The following is a description of a gene set: Genes predicted to be targets of miRBase v22 microRNA hsa-miR-454-3p in miRDB v6.0 with MirTarget v4 prediction scores > 80 (high confidence targets). studied in species Homo sapiens Human Gene Set: MIR454_3P from publication Chen Y, Wang X (PMID 31504780), and this is the list of marker genes: YTHDF2, SNPH, KIAA1217, HECW2, MBNL3, IGF1, TMEM170B, NPTN (NCBI Gene Id 27020), SNX2, TENT2, ZEB2, FRMD6, SBNO1, DCBLD2, THOP1, TRIM2, KLHL3, ANKIB1, RRAGD, DAAM1, ZCCHC14, TANC2 (tetratricopeptide repeat, ankyrin repeat and coiled-coil containing 2), RAB12, ITGB8, OSBPL6, CEP170 (NCBI Gene Id 9859), IKZF5, RACGAP1, PIKFYVE, CYSLTR1, KBTBD8, STIM2, TOGARAM1, AGO1 (NCBI Gene Id 26523), ZMAT3, PGM2L1, TSHZ1, DGKE, TBL1XR1, CHMP3, TMEM250, ACVR1, AAK1, TMEM9B, MED12L, BPTF, SH3D19, C2orf15, TGFBR1, MTMR10, BTBD7, SLAIN1, TAFA1, LSMEM1, BAG5, ELK3, PDZD11, MDM4, PHACTR2, LGALSL, LRP2 (NCBI Gene Id 4036), CENPO, TFCP2L1, PTPN4, HCFC2, PLCB1, R3HDM1, SLC2A4RG, SYT6, TMEM50B, ACBD3, SALL3, CCNY, RBBP8, CREB5, SOS2, PRUNE2, CD69, LRRTM2, WDR20, RFX7, ARHGEF4, WEE1, UBE2D2, CD2AP (NCBI Gene Id 25916), USP28, ZBTB4, ARHGEF26, NSD3, TMOD1, LDLR, LPGAT1, RTCA, LRP8, MYBL1, NABP1, HPRT1, MCTP1, TACC2, KIAA1191, CCDC6, ST8SIA5, ABCB7, RNF216, MDFIC, SPOCK1, CPEB1, PPP6R2, SCUBE3, PIP4P2, ARHGAP21, EPS15, FYN, PCNX1, BLCAP, INO80, KCNA4, PPARG, ITPR1, USP33, PLAA, CBY1, ARHGAP12, PURG, NRBF2, SHANK2, ATG16L1, MAP3K20, SFMBT1, DGKH (diacylglycerol kinase eta), POU4F1, ERP44, ABRAXAS2, TEX2, RUNX3, DCAF8, ABHD3, CNOT6, HS3ST5, FERMT2, LCORL, KDM2A, OTUD3, MBD2, MFSD6, CLCN6, POP7, EBF3, BRWD1, CFL2, FAT3, SERBP1, CRACD, CBX6, DEPDC1, SOCS5, LRIG1, WDFY3, TRPC3, EIF4E2, NFIB, ENPP5, HOXD1, INHBB, FMC1, CLIP1, UNC13A (unc-13 homolog A), STX6, EMX2, TRIM23, ERCC4, TGFBR2, BTF3L4, RNF38, DENND4C, BHLHE41, TES, DSG1, VCF1, ACSL1, TSC1, HOXA3, POU3F2, SNIP1, LMLN, MB21D2, ZNF3, PIGA, AKAP11, ASXL2 (ASXL transcriptional regulator 2), ESR1, TNRC6C, FRZB, GAREM1, BAHD1, RTN1, MIGA1, BMPR2, ZNF862, KATNBL1, HSPA8, PHF12, AKAP1, CBFB, SESTD1, DLC1, SPART, PRKAA1, PTP4A1 (NCBI Gene Id 7803), TLCD3A, EGLN3, JADE1, SNX31, NPNT, ATP12A, DSEL, VGLL4, UBXN2B, DPYSL2, NACC2, MLLT6, FBXO28, GJA1, RASD1, NHLH2, ADAM12, NFIA, MECP2, ALDH3A2, SYBU, DDX6, ZNF594, PMEPA1, FOSL1, RAP2C, MIER1, PRKD3, RAPGEF4, TET3, CYP2U1, SECISBP2L, JARID2, DYNLL2, IGSF3, RNF145, SRSF2, PAK6, CALM2, LRRK2, BTG1, PHF14, GTF2H1 (general transcription factor IIH subunit 1), CDS1, RBM25, SULF1, G3BP2, BRWD3, PHF3 (PHD finger protein 3), CNOT7, LDAF1, NPEPL1, EOGT, SAMD8, CLCN5, ZBTB18, UBA3, MACIR, MID1IP1, CASD1, SNX5, ARL6IP1, UBE3B, FMR1, ADGRB3, MBNL1, NECTIN3, ING2, BTBD3, AGO4, DNAJC16, BMP3, DYNC1LI2, FUT9, PIK3C2A (phosphatidylinositol-4-phosphate 3-kinase catalytic subunit type 2 alpha), HIVEP2, DIAPH3 (NCBI Gene Id 81624), SPEN, NALF1, ZNF800, RASA1, PHAF1, NKAPD1, RO60, SLC44A1, CGGBP1, CLCN3, USP8 (NCBI Gene Id 9101), LDLRAD4, USP13, MET, FBXO48, PSAP, WDR47, SERINC3, IL1RAP, G0S2, SPTY2D1, WNK1, SMOC1, CPEB2, CBLB, VPS13D, PHF20, LRP6, ARHGAP1, ZIC5, CAMSAP2, SNAP47, SZRD1, LY75, DENND10, FASTK, MAP3K12, PPFIA2, WDR33, FZD6 (NCBI Gene Id 8323), AGFG1, PIK3CB, UBE2W, ZFYVE9, NCKAP5, ULK2, TTYH3, ZNF107, PPP1R15B, ABCC5, KMT2C, JMY (junction mediating and regulatory protein, p53 cofactor), NEUROG1, WNT1, STON2, CHD5, ADCY1, KIF13A, FOXF2, PSD, CSMD1, MMGT1, ROBO2, SKIDA1, DLL1, ATG14, PDIK1L, HEG1, AR, ACSL4, SPATA2, FIBIN, DCUN1D3 (defective in cullin neddylation 1 domain containing 3), EREG, MIGA2, GPR65, INSIG1, ZNF555, IRF1, SPHK2, MAPK1, SLMAP, MEMO1, AKIRIN2, LONRF3, IMPDH1, DLG5, UBB, ATP6V1B2, ITPRIPL2, SIX4, CLTC, GADD45A, MPHOSPH9, IL15, SMARCD2, SEL1L3, RAI2, ERBIN, MTCL1, PTPRG, KRTAP26-1, EPC2, PTGES3, SBF2, KLF7, NPAT, ACBD5, RAD51B, MAF (NCBI Gene Id 4094), EDN1, ZNF217, RPS6KA5, SAR1B, ZNF609, DOCK3, DNAL1, ST18, THSD7A, DICER1 (NCBI Gene Id 4333), PEX5L, MSMO1, FSTL5, CUL3, HECA, RAB5A, APCDD1 (NCBI Gene Id 85500), CNOT4, SAMTOR, CDK19, CHST1, RALGPS2, PAN3, CAPRIN2, APPL1, CPEB3, ZFYVE26, ARAP2, CCDC126, RAB30, LRP12, SLC6A6, ZBTB20, BTAF1, MAT2B, ABCE1, VPS37A